The following is a description of a gene set: Comprehensive identification of all functional elements encoded in the human genome is a fundamental need in biomedical research. Here, we present a comparative analysis of the human, mouse, rat and dog genomes to create a systematic catalogue of common regulatory motifs in promoters and 3' untranslated regions (3' UTRs). The promoter analysis yields 174 candidate motifs, including most previously known transcription-factor binding sites and 105 new motifs. The 3'-UTR analysis yields 106 motifs likely to be involved in post-transcriptional regulation. Nearly one-half are associated with microRNAs (miRNAs), leading to the discovery of many new miRNA genes and their likely target genes. Our results suggest that previous estimates of the number of human miRNA genes were low, and that miRNAs regulate at least 20% of human genes. The overall results provide a systematic view of gene regulation in the human, which will be refined as additional mammalian genomes become available. Genes having at least one occurrence of the highly conserved motif M126 WYAAANNRNNNGCG in the regions spanning 4 kb centered on their transcription starting sites. The motif does not match any known transcription factor binding site. from publication Xie X, Lu J, Kulbokas EJ, Golub TR, Mootha V, Lindblad-Toh K, Lander ES, Kellis M (PMID 15735639) studied in species Homo sapiens Human Gene Set: WYAAANNRNNNGCG_UNKNOWN, and this is the list of marker genes: STK35, HYAL2, CDKN2C (cyclin dependent kinase inhibitor 2C), NR4A1, C6orf62, CSTF3, SZRD1, TLCD4, RHOB, CTCF, PHC2, RFX1, GIT1, NEFM, SLC43A2, DCP1A, E2F8, PPP2R5E, PCF11, TLNRD1, C1QTNF7, RFX4, LRRN2, KDM2A, ERF, HNRNPA0, DUSP6, CBLN4, MGLL, ULK1, HOXA5, EFNB3, FERMT2, BARHL2, SUPT4H1, SRSF3, GABRA1, ATL2, SOCS2, VASH1, CDC20B, ST8SIA2, NEUROD1, LMO4, LGR5, PHF21B, HOXD3, BMI1, NOL4, PHOSPHO1, SMC3, AHCYL2, PPFIA2, MB21D2, GABRB2, ETV6, PHOX2A, SMAD6, ROR1, ELK3, NDUFA4L2 (NCBI Gene Id 56901), TMEM184B, C1orf43, RCOR2, KANSL3